Given this list of marker genes Osbpl11, Plin3, Plin5, Abhd5, Trem2, Pnpla2, Ppara, Pparg, Osbpl8, Plin2, Lpl, Apoc4, here is a description of the gene set: Mouse Gene Set: GOBP_REGULATION_OF_TRIGLYCERIDE_STORAGE studied in species Mus musculus Any process that modulates the rate, frequency or extent of sequestering of triglyceride. Triglyceride sequestration is the process of binding or confining any triester of glycerol such that it is separated from other components of a biological system.